Given this list of marker genes Inpp4a, Ms4a6b, Ctsc, Fam8a1, Zfp90, Atp6v1a, Ogt, Ranbp2, Igf2r, Selenop, Pdgfc, Rtn3, Ppp3r1, Parp12, Lamp2, Hck, Ifi204, Gga1, here is a description of the gene set: Cytokines mediate cell-cell communication in the immune system and represent important therapeutic targets. A myriad of studies have highlighted their central role in immune function, yet we lack a global view of the cellular responses of each immune cell type to each cytokine. To address this gap, the authors created the Immune Dictionary, a compendium of single-cell transcriptomic profiles of more than 17 immune cell types in response to each of 86 cytokines (>1,400 cytokine-cell type combinations) in mouse lymph nodes in vivo. A cytokine-centric view of the dictionary revealed that most cytokines induce highly cell-type-specific responses. For example, the inflammatory cytokine interleukin-1β induces distinct gene programmes in almost every cell type. A cell-type-centric view of the dictionary identified more than 66 cytokine-driven cellular polarization states across immune cell types, including previously uncharacterized states such as an interleukin-18-induced polyfunctional natural killer cell state. from publication Cui A, Huang T, Li S, Ma A, Pérez JL, Sander C, Keskin DB, Wu CJ, Fraenkel E, Hacohen N (PMID 38057668) Genes positively differentially expressed in cell type: Macrophage upon treatment with cytokine: PRL in mouse lymph nodes in vivo. species: Mus musculus Mouse Gene Set: CUI_MACROPHAGE_PROLACTIN_RESPONSE_UP